Given this list of marker genes MIR211, GOLGA8G, DNM1P50, ENSG00000206849, ABCB10P3, GOLGA8F, OTUD7A, MPHOSPH10P7, RPL41P2, ENSG00000207430, GOLGA8N, LINC03034, RNU6-17P, ENSG00000212415, RN7SL286P, RN7SL796P, GOLGA8T, RN7SL539P, GOLGA6L23P, LCIIAR, ARHGAP11A-DT, ARHGAP11A, FMN1, RN7SL238P, ENSG00000207432, ARHGAP11A-SCG5, WHAMMP2, GREM1-AS1, HERC2P10, TJP1, TRPM1, ENSG00000206987, GOLGA8R, DNM1P30, ABCB10P4, ARHGAP11B-DT, NSMCE3, DEPDC1P1, RN7SL673P, NCAPGP2, HERC2P11, GOLGA8K, LINC02352 (NCBI Gene Id 102725022), RN7SL628P, GOLGA6L7, LINC02249, MPHOSPH10P2, FAN1, RNU6-466P, RN7SL82P, GOLGA8O, RYR3-DT, DNM1P32, RN7SL185P (NCBI Gene Id 106479289, RNA, 7SL, cytoplasmic 185, pseudogene), TUBBP8, TMCO5B, SCG5, ENSG00000187951, PDCD6IPP2, ULK4P3, APBA2, RN7SL719P, ENSG00000297232, OCA2, ULK4P1, MTMR10, GOLGA6L24 (golgin A6 family like 24), GOLGA8J, RN7SL196P, HERC2P9, GOLGA8H, RN7SL469P, KLF13, GOLGA8UP, SYNGR2P1, RPL5P32, WHAMMP4, ENSG00000238519, DNM1P28, ENTREP2, ARHGAP11B, HERC2, UBE2CP4, CHRNA7, RYR3, GOLGA8M, GOLGA6L25, SCG5-AS1, HNRNPA1P71, CHRFAM7A, MIR4509-3, ULK4P2, RNU6-18P, WHAMMP1, MPHOSPH10P3, HERC2P1, TMEM183AP3, MIR4509-2, LINC02256, GREM1, GOLGA8Q, HMGN2P5, DNM1P31, here is a description of the gene set: Human Gene Set: chr15q13 studied in species Homo sapiens